Given this list of marker genes Sfrp1, Kremen2, Ccr1l1, Enpp1, Gfra4, Rflna, Adrb2, Srgn, Sox9, Rflnb, Smurf1, Gdf10, Nfe2, Hif1a, Vdr, Lrp4, Tgfb1 (transforming growth factor, beta 1), Bcl2, Notch1, Smad3, Ltbp3, Ahsg, Kremen1, Bcor, Smad7, Calcr, Dlk1, Chsy1, Pth, Mepe, Rbpj, Cyp27b1, Acvr2b, Grem1, Mkx (NCBI Gene Id 210719), Mef2c, Smad6, Tph1, Calca, Dkk1, Gata1, P2ry2, Ccr1, Tmem53, Fgf23, Mdk, Trpm4 (transient receptor potential cation channel, subfamily M, member 4), Acvr1b, Sost, Smad2, Ecm1, Ptk2b, here is a description of the gene set: Mouse Gene Set: GOBP_NEGATIVE_REGULATION_OF_OSSIFICATION Any process that stops, prevents, or reduces the frequency, rate or extent of ossification, the formation of bone or of a bony substance or the conversion of fibrous tissue or of cartilage into bone or a bony substance. studied in species Mus musculus